Given this list of marker genes HSD3B1, CYP11A1, KRT18, GFRA1, CCNA2, here is a description of the gene set: Accumulating evidence suggests that regulation of RNA processing through an RNP-driven mechanism is important for coordinated gene expression. This hypothesis predicts that defects in RNP biogenesis will adversely affect the elaboration of specific gene expression programs. To explore the role of RNP biogenesis on mammalian development, we have characterized the phenotype of mice hypomorphic for Thoc1. Thoc1 encodes an essential component of the evolutionarily conserved TREX complex. TREX accompanies the elongating RNA polymerase II and facilitates RNP assembly and recruitment of RNA processing factors. Hypomorphic Thoc1 mice are viable despite significantly reduced Thoc1 expression in the tissues examined. While most tissues of Thoc1-deficient mice appear to develop and function normally, gametogenesis is severely compromised. Male infertility is associated with a loss in spermatocyte viability and abnormal endocrine signaling. We suggest that loss of spermatocyte viability is a consequence of defects in the expression of genes required for normal differentiation of cell types within the testes. A number of the genes affected appear to be direct targets for regulation by Thoc1. These findings support the notion that Thoc1-mediated RNP assembly contributes to the coordinated expression of genes necessary for normal differentiation and development in vivo. from publication Wang X, Chinnam M, Wang J, Wang Y, Zhang X, Marcon E, Moens P, Goodrich DW (PMID 19307311) Genes up-regulated in testis tissue expressing hypomorphic allele of THOC1. Human Gene Set: WANG_THOC1_TARGETS_UP studied in species Homo sapiens